Given this list of marker genes COL5A1, CNN3, MAP1S, ARID3B, SFXN2, NSG2, FOXP1, RPL6, MYCBP2, DUSP6, TTC3, IGHM, SLC11A2, ZMYND11 (zinc finger MYND-type containing 11), IPO4, TEC, TSR1, EVL, SATB1, RPL5, CAMSAP1, ST6GAL1, RNF38, CD7, IDUA, CTSS, MFN1, OVGP1, RPS3A, MIA3, PHETA1, CRLF3 (NCBI Gene Id 51379), KCTD12, PISD, RETREG1, ANKRD10, WIPI2, ARRB1, ABCG1, SMAD1, ZYG11B, DNAAF10, MGST2, ITGAE, P4HA1 (prolyl 4-hydroxylase subunit alpha 1), PCCB, EGR2, GSN, DNTT, PARP8, SLC44A1, CLIP1, SETD6 (NCBI Gene Id 79918), RBM38, PKD1, FNTB, PELI1, ATP13A1, PAN2, MYC, RACK1 (NCBI Gene Id 90938), SLC12A7, NIT2, HSD17B7, P2RX4, MCCC1, RPS8, ABCC5, RFLNB, RPS6, POU2AF1, TOMM34, RERE, XPC, TAPBP, GADD45A, SKI, IKBKE, NOMO1, GALNT11, KCNN4, TLR6, CRAMP1, DVL1, SRCAP, ZKSCAN3, IGF1R, PRKD2, NCOA5, GGA2, LEF1, CYTH3, ABLIM1, IL6ST (NCBI Gene Id 3572), MAP4K3, NOTCH1, PTOV1, RPL10, EYA2, CCR9, CASK, SIPA1L2, SF3B3, ZBTB20, MSH3, NR2C1, SELL, WFS1 (NCBI Gene Id 94141), FRMD8, TIA1, ETS2, ADCY6, DPH5, CXXC5, IFT81, PLEKHA1, NLK, DNAJB2, CCND2, NEDD4L, DHX30, CFLAR, FBXO21, TCF4, EVI5 (NCBI Gene Id 7813), PDK1, POU2F1, NDUFAF4, MARCKS, RCC2, EPHX1, VKORC1, METTL9, ACYP1, KMT2A (NCBI Gene Id 79951), TCP11, SESN1, ZNRF1, IL7R, DDC, MAT2A, RPS19, TMEM245, RGCC, HLA-DOB, RALGPS2, HSD17B11, DGKA, RAB3IP, CHERP, EEIG1, C19orf48P, BZW2, RPS6KC1, SSBP2, HAGH, TP53, MFHAS1, APP, PIP4K2A, RPS3, PATJ, SMAD7, BCKDHB, IL4R, DCP1A, CYP2J2, DALRD3, PRMT3, WLS, RAMP1, RPL14, STX1A, RABGAP1L, AKAP9, LIPA, CLK4, CD72, SURF6, CTSV, TCF7, CCR7, WDR74, TSPAN13, MDM4 (NCBI Gene Id 4194), EML5, IL6R, AMPD3, DNAJC7, RPS4X, RNF141, ZFP36, CNOT4, DDIT4, NUMA1, CNGA1, MAP7, WDR6, SKIC2, PPTC7, here is a description of the gene set: from publication Kaech SM, Hemby S, Kersh E, Ahmed R (PMID 12526810) species: Homo sapiens Human Gene Set: KAECH_NAIVE_VS_DAY8_EFF_CD8_TCELL_UP Genes up-regulated in naïve CD8 T cells compared to effector CD8 T cells at the peak expansion phase (day 8 after LCMV-Armstrong infection). How and when memory T cells form during an immune response are long-standing questions. To better understand memory CD8 T cell development, a time course of gene expression and functional changes in antigen-specific T cells during viral infection was evaluated. The expression of many genes continued to change after viral clearance in accordance with changes in CD8 T cell functional properties. Even though memory cell precursors were present at the peak of the immune response, these cells did not display hallmark functional traits of memory T cells. However, these cells gradually acquired the memory cell qualities of self-renewal and rapid recall to antigen suggesting the model that antigen-specific CD8 T cells progressively differentiate into memory cells following viral infection.